Given this list of marker genes ST20, BCL3, TP53, ERCC5, BAK1, MDM2, DCUN1D3, POLH, YY1, HMGN1, PIERCE1, MAP3K4, WRN, EI24, BRCA2, here is a description of the gene set: studied in species Homo sapiens Human Gene Set: GOBP_RESPONSE_TO_UV_C Any process that results in a change in state or activity of a cell or an organism (in terms of movement, secretion, enzyme production, gene expression, etc.) as a result of a UV-C radiation stimulus. UV-C radiation (UV-C light) spans the wavelengths 100 to 280 nm.